The following is a description of a gene set: MECP2 regulates neuronal receptors and channels species: Homo sapiens Human Gene Set: REACTOME_MECP2_REGULATES_NEURONAL_RECEPTORS_AND_CHANNELS, and this is the list of marker genes: CREB1, MECP2, MET, PTPN4 (protein tyrosine phosphatase non-receptor type 4), OPRM1, GRIN2B, GPRIN1, NOTCH1, HDAC2, HDAC1, OPRK1, FKBP5, PTPN1, TRPC3, GRIA2, SLC2A3, GRIN2A, SIN3A